Given this list of marker genes DNAJB13, FOXJ1, TRAF7, DNAH9, SH3PXD2B, ZMYND10, PLXND1, ODAD4, GATA6, SMAD2, CTU2, RSPH4A, SPEF2, P4HA2, DNAI2, CFAP298, CHD7, DVL3, DNAL1, STK36, PKD1L1, DNAAF3, RAI1, OTUD5, DRC1, DNAAF6, ODAD2, ATP6V1B2, PTPN22, RPGR, MMP14, HYDIN, RSPH3, TMEM94, CFAP53 (cilia and flagella associated protein 53, NCBI Gene Id 220136), PIGL, CCNO, TBC1D24, CFAP221, ODAD3, RSPH1, DAW1, NKX2-6, WASHC5, CCDC39, TTC12, SPAG1, CFAP74, NODAL, HLA-B, ODAD1, DNAAF4, NKX2-5, OFD1, RSPH9, EIF2AK3, DNAAF11, UBE2A, PEX19, DNAH5, MCTP2, BCOR, CCDC40, DNAI1, GNB2, TBX5, IPO8, PLCH1, MCIDAS, GATA5, MMP2, DNAH11, GDF1, NEK10, CFAP300, GAS2L2, TBX1, NOTCH1, ZIC3, CFC1, HLA-DRB1, DNAAF5, STAG2, DNAAF2, NADSYN1, NME5, DNAAF1 (NCBI Gene Id 123872), TBX2, NME8, PAH, DNAH1, CIROP, LRRC56, here is a description of the gene set: Congenital malformation of the right heart studied in species Homo sapiens Defect or defects of the morphogenesis of the right heart identifiable at birth. Human Gene Set: HP_CONGENITAL_MALFORMATION_OF_THE_RIGHT_HEART